Given this list of marker genes Polr2l, Gtf2f2, Polr2f, Polr2c, Polr2g, Ncbp1, Ptbp1, Polr2a, Polr2k, Ncbp2 (NCBI Gene Id 98015), Polr2e, Polr2i, Polr2d, Polr2b, Gtf2f1 (NCBI Gene Id 98053), Polr2h, Hnrnpa1, here is a description of the gene set: FGFR2 alternative splicing Mouse Gene Set: REACTOME_FGFR2_ALTERNATIVE_SPLICING species: Mus musculus